The following is a description of a gene set: Any process that stops, prevents or reduces the frequency, rate or extent of adipose tissue development. Human Gene Set: GOBP_NEGATIVE_REGULATION_OF_ADIPOSE_TISSUE_DEVELOPMENT species: Homo sapiens, and this is the list of marker genes: PARP1, POU4F2, SPI1, INHBE, KLF7, MIR138-1